The following is a description of a gene set: species: Homo sapiens Botulinum toxin type G (botG) is rarely if ever associated with human disease and a pathway by which it might enter the circulation from the human gut has not been described. Nevertheless, the toxin itself, a disulfide-bonded heavy chain (HC) - light chain (LC) heterodimer ("dichain"), is capable of binding to neurons by interactions with cell-surface ganglioside and syntagmin 1 (SYT1), the bound toxin can enter synaptic vesicles and release its LC moiety into the cytosol of targeted cells, and the botG LC can cleave vesicle-associated membrane proteins 1 and 2 (VAMP1 and 2) on the cytosolic face of the synaptic vesicle membrane. These four events are annotated here. Reactome Pathway: Toxicity of botulinum toxin type G (botG) part of: Neurotoxicity of clostridium toxins, and this is the list of marker genes: VAMP1, SYT1 (synaptotagmin 1), botG, VAMP2